Given this list of marker genes CELF2-AS2, BBLNP1, MED21, ZNF675, RNU6-612P, ENSG00000200235, LUZP1, GLG1, TPM4P1, OR1X5P, SPEG, ADA, FOXP1-AS1, AGMAT, FABP5P3, LTK, MLST8, TGFB1, OR7A17, JHY, RRN3P1, HEBP2, GALNTL5, MIX23, TCEAL8P1, SNAP25, RND1, PFAS, PMM1, SSX7, GAS8, JAZF1-AS1, LYN, MIR3529, TRIM55, YAP1P1, RN7SL93P, RNU6-1340P, H3P44 (NCBI Gene Id 347376), SPATS2L, MCTS1, RNU1-141P, MTO1, QSER1, AP1S3, SPMIP10, TRAV15, VOPP1, GC, TTC1, DAZAP2, C6orf141, ZEB2P1, ITIH3, OR5AQ1P, ENSG00000243004, KRT18P45, ACACA, MAP4K5, SDC4, RNU6-386P, LINC01641, LINC02390, DUS2, DHTKD1, DAGLB, C2CD5-AS1, EXOSC2, VPS39, NPLOC4, ITGAL-AS1, ALDOA, RNA5SP474, ST7L, SLC25A16, SHOC1, SLC6A1, MIR4510, AGAP5, ENSG00000265246, SLFN12, FMN2, IFT57P1, ELAC2, RNU6-166P, RPL36P2, MTND1P14, WNT8A, GDPD5, FES, CNDP2 (carnosine dipeptidase 2), TNRC18, CASD1, SYCE2, SAMD13 (NCBI Gene Id 148418), RNU6-847P, SRRM2-AS1, UTP4, CXXC1, LINC00581, GIT2, SNORD81, CCDC65, LINC01485, SNHG30, ITGAM, HAPLN2, BORCS6, UMOD, SDAD1P3, SRSF8CP, LYPLA2P1, GLRX5P2 (NCBI Gene Id 118568821), CMKLR2-AS, AKAP9, CYP1B1-AS1, EIF3F, GTF2I, TPRXL, RNU6-1003P, RN7SL344P, CD160, LIM2-AS1, NAPSA, DOCK8-AS2, GABARAPL3, SH2B3, CDCA7P1, NLE1, SRRM2 (NCBI Gene Id 51462), TNFRSF10B, EGFEM1P, PLA2G4C, ARPC1A, GXYLT2, TNFRSF12A, CWC25, CEACAM21, RFC1, TTLL13, MTFMT, SLC22A11, LINC01235, MB, IGSF21, PTPN2, LINC00929, MIR3611, CTNNA2, DDX46, LINC02576, MIR3908, KAT8, FAM177A1P1, RORA, NUCB1-AS1, CROCCP3, ENSG00000233242, CFAP299, CCDC40, ZNF863P, RNU4-62P, RB1CC1, RNU6-916P, ILDR1, PLA2G15, PPATP1, FCHO2 (NCBI Gene Id 115548), LPGAT1, TOP3B, ARMH3, TMX1P2, PCBP1-AS1, MIR3162, AURKB, CLDN23, CENPV, TRPV1, TMEM98, MIR764, SCN3B, COQ10A, PPP1R42, TRIM15, RPS27P6, NOL6, LIPA, CCNB3, GDI2, OR1X1P, ATP9B, ENSG00000187951, ANGEL1, COPS3, RPL39P18, ASS1P5, RLIG1P2, TRPM6, MORF4L1P5, RN7SKP270, ENSG00000202059 (NCBI Gene Id 124900525), HNRNPMP2, ESPN, DNAI4, IL16, PPIP5K2, H3P10, NPAT, FRMD7, PTK2B (NCBI Gene Id 5748), PRAMEF29P, SMCR2, ANGPTL6, CDK4, ENSG00000244137, C1orf87, PVT1, RPL32P27, COPS5P1, STX4, SOX9-AS1, ACER3, NFYC, RPL36, YEATS2, here is a description of the gene set: Human Gene Set: ZNF426_TARGET_GENES Genes containing one or more binding sites for (ZNF426) in their promoter regions (TSS -1000,+100 bp) as identified by GTRD version 20.06 ChIP-seq harmonization. from publication Yevshin I, Sharipov R, Kolmykov S, Kondrakhin Y, Kolpakov F (PMID 30445619) species: Homo sapiens